The following is a description of a gene set: Human Gene Set: GOCC_CILIARY_ROOTLET studied in species Homo sapiens A cytoskeleton-like structure, originating from the basal body at the proximal end of a cilium, and extending proximally toward the cell nucleus. Rootlets are typically 80-100 nm in diameter and contain cross striae distributed at regular intervals of approximately 55-70 nm., and this is the list of marker genes: SPAG5, KIF5C, CROCC, KLC3, PSEN1 (NCBI Gene Id 5663), PJVK, RAB28, ODAD3, KIF5B, KIF5A (kinesin family member 5A), NEK4